Given this list of marker genes EMX2, SIX3, TUBB2B, COL4A1, WNT1, COL4A2, WDR62, EPG5, KIF26A, here is a description of the gene set: The presence of a cleft in the cerebral cortex unilaterally or bilaterally, usually located in the frontal area. species: Homo sapiens Human Gene Set: HP_SCHIZENCEPHALY Schizencephaly